Given this list of marker genes AKT1, SALL4, CHN1, MAFB, PNPLA6, here is a description of the gene set: Central heterochromia The presence of distinct colors in the central (pupillary) zone of the iris than in the mid-peripheral (ciliary) zone. species: Homo sapiens Human Gene Set: HP_CENTRAL_HETEROCHROMIA